Given this list of marker genes ISX, NELL2, PCLO, RFX7, POGLUT3, ATP11C, LIMS1, AKAP5, EPC2, FAM43A, AUTS2, GRIK2, KDELR2, ARRDC2, PTPRD (NCBI Gene Id 5789), MS4A13, FOXN3, MRPS33, ZSWIM6, FST, SECISBP2L, CNOT7, MARK3, CHODL, CDC42EP3, PDS5A, TASOR, ZNF85, GTF2H1, EIF4G2, SACM1L, ASH1L, OXTR, CGGBP1, AMPH, LCOR, GP6, GATM, KCNN3, SEMA6D, BRWD3, HACL1, SLC4A7, AGFG1, BCL7A, JADE1, DKK2, ADAM19, C19orf44, SCN3A (NCBI Gene Id 6328), CUL4A, LACTB, RAB22A, RALA, NPAT, FCRL3, PLXNC1, CAMK4, RARG, CUL1, ENDOD1, ZDHHC17, ADAM10, CBX4, EOGT, CLCN4, ADAM17, PDE6C, PDE10A, HIPK1, CLOCK, ALPI, RWDD2A, KIAA0753, VOPP1, REV3L, KIAA0232, LRRN1, USP9X, AGPAT5, CTNNA2, C2orf74, ATRN, PGRMC1, KPNA1 (NCBI Gene Id 3836), AKIRIN1, TMEM245, PCDH19, UNKL, PLXNA4, CCDC6, ATXN7, BACH2, DMRTC1, RPS6KB1, ARID1A, MBNL3, TLCD4, RGMB, CHRNA3, UBA6, KRBOX4, GGNBP2, MACO1, SLC1A2, OLIG3, DENND1B (DENN domain containing 1B), LCLAT1 (lysocardiolipin acyltransferase 1), UNC13A, SLITRK4, ZFP1, SORBS2, TRIP13, TSPYL4, BCL11A, MAP4, PTPRM, PRKACB, LHX8, SGMS1, GEM, ANKRD12 (ankyrin repeat domain 12), UVSSA, SENP7, THAP6 (NCBI Gene Id 152815), CAMTA1, PPP1R3D, C14orf28, SCYL2, PAX6, MEIS1, AGO3, RBPJ, FLT1, TNPO1, PPHLN1, NUP43, PDE3A, PF4, LONRF2, PCDH9, PJA2, POLR1D, BPTF, GRIP1, GRP, ANK3, SPTBN4, MDGA2, CSMD1, CASP7, DFFB, SCLT1, RIMS2 (regulating synaptic membrane exocytosis 2), OLFML2B, RASSF5, DMRTC1B, PTBP1, FGFBP3, GLRA3, NCEH1, AADAT, SCN1A, TET1, TAOK1, GMFB, TFRC, NR2C2, STAT5B, RBMS3, DAB2IP, EEF2KMT, AMN1, LPGAT1, AGAP1 (ArfGAP with GTPase domain, ankyrin repeat and PH domain 1), HOMER1, PRDM1, RB1 (RB transcriptional corepressor 1), KHDRBS3, VPS36 (vacuolar protein sorting 36 homolog), ZNF268, DMRT2, DYRK1A, PNN, MOB1B, C1orf74, CACNA2D1, CCDC9B, LUM, ZBTB5, SP3, SYT14, CXCR6, ZNF440, FOXD4L3, IRF2BPL, C3orf80, CRTAM (cytotoxic and regulatory T cell molecule), MED13L, SNX13, WAC, TRIM63, WWP1, MTDH, PNPT1, PRKCE, RUNX1 (RUNX family transcription factor 1), KMT5B, MTF1, DHRS12 (NCBI Gene Id 79758), NEXMIF, CNKSR2, CPSF6, MLLT11, ELK3, UBE3A, PIWIL4, ZER1, NWD2, DLK1, XRCC4, BCL2, RALBP1, KCTD1, TRPM1, here is a description of the gene set: from publication Chen Y, Wang X (PMID 31504780) Genes predicted to be targets of miRBase v22 microRNA hsa-miR-557 in miRDB v6.0 with MirTarget v4 prediction scores > 80 (high confidence targets). Human Gene Set: MIR557 species: Homo sapiens